Given this list of marker genes Ccl21a, Tirap, Cd74, Ccl28, Vav1, Mdk, Cd99l2, Trem1, Ptger4, Cxadr (NCBI Gene Id 70446), Fam3d, C1qbp (complement component 1, q subcomponent binding protein), Myo1f, Pde4b, Lyst, Ptger3, Camk1d, Zpld2, Ccl21d, Cxcl13, Srp54a, Ppbp, Ccl22, Pde4d, Ccl5, Cxcl1 (C-X-C motif chemokine ligand 1), Thbs1, Il4, Mapk1, Sirpa, Trpv4, Cxcl9, Prex1, Ccl19-ps5 (NCBI Gene Id 100039789), Cxcl10, Epx, Sell, Syk, Ppib, C3ar1, Mstn, Vav3, Mpp1, Ccl21e, Slit2, Ifng (interferon gamma), Il34, Jagn1, Thbs4, Ccl8, Edn3, Tlr2, Ccl3, Ccl24, Perp, Gbf1, Tnfsf18, Itgam, Itga1, Tnfaip6, Nckap1l, Il17a, Cxcr2, Dpp4, Mcu, Bsg, Jam3, Emp2, Anxa1, S100a9, Itgb2l, Pikfyve, Cxcl5, Jaml, Il17b, Spp1, Ccl19-ps3, Ccl21b, Rac3, Slamf8, Csf3r, Prtn3, Ccl19-ps6, Cklf, Gp2, Trem3, Ccl7, Lbp, Ednra, Itga9, Ccl1, Lgals3, Akirin1, Umod, Ccl19-ps1, Fcgr3, Ptprj, Slc37a4, Dapk2, Ccl2 (C-C motif chemokine ligand 2), Scg2, Ccl21f, Il1b, C5ar1, Ccr7, C5ar2, Ccl19, Ccl4, Ccl12, Ccl19-ps4, Pf4, Cd300a, Dysf, Ccl11, Cxcl3, Ripor2, Fut7, Il23a, Ppia, Slamf1 (signaling lymphocytic activation molecule family member 1), Ccl27a, Cxcl15, Prkca, Dnm1l, Fut4, Rac2, Il17ra, Rtn4, Cxcl17, Mapk3, Selenok, Wdr1, Pecam1, Rarres2, Rac1, Bst1, Irak4, Ccl26, Fcer1g, Edn1, Cx3cl1, Vegfa, Xcl1, Nod2, Cxcl2, Adam8, Tgfb2, Mcoln2, Cd177 (CD177 antigen), Cmklr1, Mospd2, Cxcr1, Edn2 (NCBI Gene Id 13615), Gm5849, Ccl25, Csf1, Ccr3, S100a8, Il1r1, Myd88, Dpep1, Il17rc, Il1a, S100a14, Itgb2 (NCBI Gene Id 16414), Csf1r, Ptk2, Pawr, here is a description of the gene set: Mouse Gene Set: GOBP_GRANULOCYTE_MIGRATION The movement of a granulocyte within or between different tissues and organs of the body. species: Mus musculus